The following is a description of a gene set: The series of molecular signals initiated by erythropoietin (EPO) binding to the erythropoietin receptor (EPO-R) on the surface of a target cell, and ending with the regulation of a downstream cellular process, e.g. transcription. species: Homo sapiens Human Gene Set: GOBP_ERYTHROPOIETIN_MEDIATED_SIGNALING_PATHWAY, and this is the list of marker genes: RHEX, STAT5B, EPOR, JAK2, EPO, KIT